The following is a description of a gene set: studied in species Homo sapiens Habitual biting of one's own body. Self-biting Human Gene Set: HP_SELF_BITING, and this is the list of marker genes: FMR1, IQSEC2, RNU4-2, NEXMIF (neurite extension and migration factor), RFX7, RAI1, FLII, DEAF1, SYT1, PIDD1, ATP1A1, NTRK1, DNM1L, CEP104